Given this list of marker genes Slc13a2, Coq8a, Ptcd2, D630039A03Rik, Gys1, Igfbp4, Esrp2, Chmp5, Nrip1, Tbl1xr1, Ndufa2, Pa2g4, Fem1a, Zswim4, Rdh9, Mindy2, Phf10, Zkscan5, Mpzl2, Sqor, Serpinf2, Col2a1, Necab1, Rhod, Uox, Stard5, Id3 (NCBI Gene Id 15903), Pla2g6, Plekha6, Il6, Bcas3, Gabarapl1, Lrp1, Mertk, Mia2, Aacs, Ppm1b, Tc2n, Rita1, Sord, Coa4, Mlxipl, Tfap4, Habp2, Isg15, Eef1b2, Hmgb2, Eif4a2, Mup1, Or10k2, Glcci1, Slc46a3, Ppp4r3b, Lrpprc, Fignl1, Odad3, Dpm1, Itih1, Per1, Cyp2a4, Foxa2, Serpinc1, H2ac11, Ttr, Fam107b, Btbd3, Nepn, Plod2, Prkar2a, Lipc, Ccr8, H13, Panx1, Ap3m1, C1ra, Ahcy, Cyp7b1, Gast, Apoe, Nfu1, Kbtbd2, Pck1, Trim13, Abhd8, Ebag9, Renbp, Ndrg2, Cd47, Cxcr4, Baat, Timm9, Mafk, Ufd1, Aqp8, Serpina1c, Apoh, Oit3, Mrps2, Cfi, Zbtb5, Acsl1, Atf4, Nr0b2, Insc, Faah, Lyn, Pparg, Tars1, Serpina3m, Mup4, Gdpd1, Col10a1, Oser1, Alkbh6, Fdft1 (farnesyl diphosphate farnesyl transferase 1), Slc25a10, Zmym1, Dhrs7, Mup2, Cdh2 (NCBI Gene Id 12558), F13b, Gpr35, Pfdn2, Stat2, Tbc1d15, Selenoo, Cdk5, Fmo2, Dram2, Gabpa, Banf1, Wdr46, Atp5pf, Ndufa8, F7, C8b, Ghitm, Gstm2, Spz1, Lifr (LIF receptor alpha), Mat1a, Klkb1, Nat8f2, Dnase2b, Foxp2, Gm14461, Bcdin3d, Tmem140, Gnl3, Afmid, Kbtbd12, Klk11, Clec2d, Mrpl36, Hivep1, Ddx3x, C4bp, Ap3s1, Clp1, Kif9, Gprc5c, Acsm3, Gpam, Mal2, Prdx6, Tjp2, Hpgd, Cth, Dad1, Ap4m1, H2aj, Omd, Hao1, Evc2, Prmt5, Tmem121b, Rdx, Vdr, Pot1a, Psmg3, Chac2, Idh2, Crkl, Scrn3, Igfbp1, Gpt, Fbp1, Mapkbp1, Tcp11l2, Clec4a2, Nr1i2, Cald1, Ugt2b34 (UDP glucuronosyltransferase 2 family, polypeptide B34), Cln8, Rpl39l, Fam43a, Klf15, Ganab, Abca1, Bnip3, Insig1, Zdhhc17, Nek8, Depp1, Cdc42ep4, Rab3b, Lrg1, Slc25a14, Cd300lf, Dhx8, Tnfrsf1a, Ambp, Ctnnbip1, Ribc1, Gcat, Dcaf11, Gramd2b (NCBI Gene Id 74540), Arhgap23, Apoa5, Pdk4, Dhcr7, Cxcl1, Aldh6a1, Pigr, Rdh1, Pigo, Zfp395, Gata3, Sin3a, Zfp950, Serpina6, Hgd, Prkdc (NCBI Gene Id 19090), Pik3ap1, Fgl2, Akt1, Pnpla2, Slc17a2 (solute carrier family 17 (sodium phosphate), member 2), Retn, Pde6d, Mug1, Brca1, Junb, Ndufs8, Rapsn, Serpina1a, Gde1, Mob2, Copg1, Vars1, Pld2, Dhx38, Itpkc, Gk, Nup43, Arhgap12, Or1o11, Dmtf1, Kng1, Insig2, Bmi1, Rab43, Cyp2c37, Ahsg, Exph5, Katnb1, Eif1a, Mt2, Plekhg3, Tpst2, H2ac8, Nkx2-5, Sar1b, Sys1, Tial1, Dcaf13, Mkks, Cyb5a, Apon, Mafg, Polr2c, Cyp3a25, Psmb10, Amfr, Atg12, Mup5, Plg, Hspa1l, Plrg1, Tmem259, Rdh16, Prl2b1, Hagh, Ddx19a, Cyp2e1, Fbxo4, Mup20, F2rl2, Stx19, Lrrk1, Ldlr, Phf20 (PHD finger protein 20), Slc25a47, Lrrc41, Cd82, Rbbp5, Cyp2a5, Inhbe, Idh1, Psen2, Pi4k2a, Kdm6b, Slc6a12, Ect2, Fmo3, Son, Prdx1, Mtx2, Prxl2c, Ces1c, Cyp4f14 (NCBI Gene Id 80440), Ugt2b35, Cd9, Sephs2, Cat, App, Fah, Zscan12, Cyp2d26, Pcgf5, Itpr1, Ftl1, Tedc2, Vps26b, Col11a1, Osbpl1a, Emc9, Timd2, Dnajb11, Trap1, Cyp2c40, Tex261, Hpx (NCBI Gene Id 15458), Aass, Per2, Klhl18, Zc3h8, Hadha (NCBI Gene Id 97212), Pon2, Cryl1 (NCBI Gene Id 97930), Serpina1b, Gimap3, Vmn2r57, Slc39a5, Il6st, Zfp113, Ppara, Chga, Slc31a1, Pros1, Tusc2, Tk1, Hacd3, Chd1, Kctd20 (NCBI Gene Id 66989), Ak3, Aldh1a1, Mxd1, Ifi27l2b, Plin2, C1rl, Pclaf, Slc37a4, Cyp2d9, Acaa1a, Cbll1, Mcm4, Psme1, Uroc1, Ttc7, Dhrs1, Ubl3, Gas1, Tsen15, Gask1a, Gfus (GDP-L-fucose synthase), Kng2, Gm10319, Efna1, Sort1, Cebpz, Herc4, Rassf6, Hps1, Trpm8, C6, Fgb, Pes1, Hbs1l, Aktip, Chuk, Sh3d19, Rdh7, Zfp111, Aldob, Fhip2a, Dph7, Cnr2 (NCBI Gene Id 12802), Cyp17a1, Lhx1, Pemt, Cs, Serpina1e, Ube2l6, Arrdc4, Thpo, Pbld1, Serpina1d, Nqo2, Nrros, Rnf4 (NCBI Gene Id 19822), Mbl2, Rpl21, Clcn7, Terf2, Itm2b, Colec12, Qsox1, Klf3, Prcc, Tst, Saa4, 1600014C10Rik, Zbtb17, Apoc1 (NCBI Gene Id 11812), H2ac13, Saa3, Hacl1, Crebl2, Cyp2c39, Eola1, Smim3, Slc25a25, Cd276, Leap2, Cish, Trp53bp2, Coch, Il11ra1, Slc25a42, Cyp2j5, Ptk2, Nuf2, Stard13, Tmem87a, Scarb1, Serpina11, Txnl4b, Cyp2d10, Cabcoco1, here is a description of the gene set: Mouse Gene Set: BOCHKIS_FOXA2_TARGETS studied in species Mus musculus from publication Bochkis IM, Rubins NE, White P, Furth EE, Friedman JR, Kaestner KH (PMID 18660816) Production of bile by the liver is crucial for the absorption of lipophilic nutrients. Dysregulation of bile acid homeostasis can lead to cholestatic liver disease and endoplasmic reticulum (ER) stress. We show by global location analysis ('ChIP-on-chip') and cell type-specific gene ablation that the winged helix transcription factor Foxa2 is required for normal bile acid homeostasis. As suggested by the location analysis, deletion of Foxa2 in hepatocytes in mice using the Cre-lox system leads to decreased transcription of genes encoding bile acid transporters on both the basolateral and canalicular membranes, resulting in intrahepatic cholestasis. Foxa2-deficient mice are strikingly sensitive to a diet containing cholic acid, which results in toxic accumulation of hepatic bile salts, ER stress and liver injury. In addition, we show that expression of FOXA2 is markedly decreased in liver samples from individuals with different cholestatic syndromes, suggesting that reduced FOXA2 abundance could exacerbate the injury. Direct targets of FOXA2 in liver, according to a ChIP-chip analysis.